Given this list of marker genes CDKN2B, PRLR, CDKN1A, CDKN2C, IRF4, CDH23 (cadherin related 23), AIP, CDKN1B, MEN1, GPR101, here is a description of the gene set: species: Homo sapiens Human Gene Set: HP_GALACTORRHEA Spontaneous flow of milk from the breast, unassociated with childbirth or nursing. Galactorrhea